Given this list of marker genes ABCA3 (NCBI Gene Id 21), ATP8B2, ATP10A, ATP8B1, ATP10B, here is a description of the gene set: Human Gene Set: GOMF_PHOSPHATIDYLCHOLINE_FLIPPASE_ACTIVITY species: Homo sapiens Catalysis of the movement of phosphatidylcholine from the exoplasmic to the cytosolic leaflet of a membrane, using energy from the hydrolysis of ATP.